Given this list of marker genes Zfp541, Shcbp1l, Catsperz, Ubb, Tesmin, Chtf18, Meiob, Meikin, Slc25a31, Dmrtc2, Zscan21, Brca2, Mlh3, Dnmt3l, M1ap, Hspa2, Tex14, Cyp26b1, Asz1, Hsf2bp, Dmc1, Ago4, Mybl1, Siah1a, Kif18a, Btbd18, Mov10l1, Fanca, Hsf5, Tdrd9, Tex15, Brdt, Ubr2, Rad51c, Atm, Rbm46, Ing2, Tdrd12 (NCBI Gene Id 73691), Rpl10l (NCBI Gene Id 639760), Ddx4, Foxj3 (forkhead box J3), Rspo1, Brme1 (break repair meiotic recombinase recruitment factor 1), Trip13, Foxj2 (NCBI Gene Id 60611), Tex19.1, Suv39h2, Meioc, Sycp2, Tdrkh, Arhgap33os, Mael, Rec8, Tex11, Mei1, Mlh1 (mutL homolog 1), Tex19.2, Spdya, Kctd19, Spo11, Sgo2a, Fignl1, here is a description of the gene set: studied in species Mus musculus A cell cycle process by which the cell nucleus divides as part of a meiotic cell cycle in the male germline. Mouse Gene Set: GOBP_MALE_MEIOTIC_NUCLEAR_DIVISION